Given this list of marker genes TGFBR1 (NCBI Gene Id 7046), THSD4, SMAD4 (SMAD family member 4, NCBI Gene Id 4089), MAT2A, NOTCH3, EFEMP1, LOX, SMAD3, FBN1, TGFB2 (NCBI Gene Id 7042), SMAD2, HEY2, PRKG1, ELN, TGFBR2, FOXC2, ACTA2, KANSL1, RASA1, MFAP5, FOXE3, MYH11, NF1, TGFB3, MYLK, here is a description of the gene set: studied in species Homo sapiens Any abnormality of the spinal meninges, the system of membranes (dura mater, the arachnoid mater, and the pia mater) which envelops the spinal cord. Human Gene Set: HP_ABNORMAL_SPINAL_MENINGEAL_MORPHOLOGY Abnormal spinal meningeal morphology